Given this list of marker genes MYOF, TNFRSF21, PNPO, CPN2, CYP27A1, TMEM19, EFHD1, CRB3, UGT8, ATF5, PKNOX1, GOLPH3L, FCGR2B, SLC25A35, DDIT4L, CABYR, CADPS, SPHK2, GPR87, PRKCD, GUCY1A1, STEAP4, BMP15, PTN, CCDC136, GPX8, NDUFC1, MMP23B, PGLYRP1, A4GALT, OTOA, RAB3D, TRAF4, ST3GAL2, UCK2, RNF186, SLC22A13, CTNNA2, ANG, DLX5, COL14A1, MAPK8IP1, GRIA2, SPTBN2, VSNL1, SPMIP5, NLRX1, TMPRSS15, B2M, ROPN1 (rhophilin associated tail protein 1), ASS1, SSTR2, GP9, ICAM5, OLIG3, AGMAT, IL5RA, ATP1B4, EPAS1, BCL2, EPYC, HOXA4 (NCBI Gene Id 3201, homeobox A4), IRAK1, PIPOX, CSF3, TMEM30B, TAPBPL, RAD23A, SMTN, TMEM35A, LBX1, METRN, ADAT1, EGFL7, NRCAM, CDH10, CAPN3, TNFSF10, ENTPD7, ATP8A2, SLC37A2, PLA2G5, IL13RA2, PLA2G12B, MYLK, DMC1, RNF183, KCNE2, PODXL, TSPYL1, DCBLD2, PTPN14, CHST2, DUSP3, CD247 (NCBI Gene Id 919), SYNGR1, PPY, CLDN9, ZCCHC18, SPR, IL2RB, MOB3B, RLN1, GPA33, P2RX5, PRM2, ETV4, ATP1B3, GDPD3, ARSA, MPV17, MORC1, NUPR1, JAK1, CSGALNACT1, SCYL1, TRIM62, ANKRD40, FMO3, WNT16, NKX2-3, TLR6, RAD51AP1, TUBA3C, REP15, CYP3A43, TRIM15, TFF3, FBXO6, DCBLD1, PRSS16, LMOD1, CRCT1, GSTA3, TMEM38A, KIF21B (NCBI Gene Id 54770), LCT, GUCA2B, FBXO21, OPHN1, EPPIN, CRHR2, ZIC3, NKAIN1, APOBEC2, PCDH8, SPINK4, KRT27, TNFAIP8L1, CCL22, DDR2, PLAUR, MSX1, TFAP2A, MAD2L2, GPLD1 (NCBI Gene Id 2822), GIT1, PIP, ARHGAP1, WNT7A, PLA2R1, GJB1, B3GALT5, SCGN, OIT3, GLUD1, LBH, MCOLN3, IL22, MXD1, SHBG, C5orf52 (NCBI Gene Id 731713), ADAD1, BHMT, SRPRB, HOXD9 (homeobox D9), HS3ST1, DPH6, ATOH1, NOP9, AKR1C3, PPARGC1A, CDCP1, ECM1, RNF144B, INSL5, STAT4, ZBTB16, CARMIL1, PTPRO, APOH, TRIM10, TST, VILL, ARPC2, EMP2, DPYSL3, SRPX, ZNF444, LGALS3BP, here is a description of the gene set: from publication Chen X, Barozzi I, Termanini A, Prosperini E, Recchiuti A, Dalli J, Mietton F, Matteoli G, Hiebert S, Natoli G (PMID 22802645) species: Homo sapiens Genes down-regulated in macrophages with knockout of HDAC3 after LPS treatment: heterozygous versus homozygous. Pan-Hdac inhibitors (HDACi) are endowed with a potent anti-inflammatory activity, but the relative role of each of the eleven Hdac proteins sensitive to HDACi to the inflammatory gene expression program is unknown. Using an integrated genomic approach we found that Hdac3-deficient macrophages are unable to activate almost half of the inflammatory gene expression program when stimulated with lipopolysaccharide (LPS). A large part of the activation defect is due to loss of basal and LPS-inducible expression of IFNb, which in basal cells maintains Stat1 protein levels, and after stimulation acts in an autocrine/paracrine manner to promote a secondary wave of Stat1-dependent gene expression. We show that loss of Hdac3-mediated repression of nuclear receptors leads to hyperacetylation of thousands of genomic sites and associated gene derepression. The upregulation of the constitutively expressed prostaglandin endoperoxide synthase, Ptgs1 (Cox-1), has a causative role in the phenotype, since its chemical inhibition reverts the Ifnb activation defect. These data may have relevance for the use of selective Hdac inhibitors as anti-inflammatory agents. Human Gene Set: GSE33162_HDAC3_KO_VS_HDAC3_KO_4H_LPS_STIM_MACROPHAGE_DN